The following is a description of a gene set: Extracellular hemoglobin, a byproduct of hemolysis, can release its prosthetic heme groups upon oxidation. Blood plasma contains proteins that scavenge heme. It is estimated that about 2–8% of the heme released in plasma becomes ‘bioavailable’, being internalized by bystander cells. If the heme degradation capacity of a cell, represented by heme oxidase 1 and 2, cannot be ramped up sufficiently then heme signaling and reactivity puts cells under stress. Platelets are activated by heme, and macrophages switch to the inflammatory type.<br><br>Free (labile) heme accumulates in the blood stream in great amounts under pathological conditions like viral infections and malaria, but also ARDS amd COPD. The locally affected cells' primary reaction is to upregulate heme oxidase 1 (HMOX1) expression. HMOX1 induction in these cells not only removes heme from circulation but also triggers a functional switch toward the anti-inflammatory phenotype. However, heme scavenging and degradation systems may get overwhelmed by the sheer amount of heme present.<br><br>Heme promotes platelet activation, complement activation, vasculitis, and thrombosis. Heme was recognized to act as a danger signal, damage-associated molecular pattern (DAMP), or alarmin and was shown to activate Toll-like receptor 4 (TLR4) signaling. It also has a role as corepressor in the circadian clock system. BACH1 is regulated by heme in a cell, thus placing heme as a signaling molecule in gene expression in higher eukaryotes. The regulation of BACH1 by heme may be important for the stress response in general.<br><br>Extracellular hemoglobin, a byproduct of hemolysis, can release its prosthetic heme groups uponoxidation. Due to the reactive nature of free heme, the blood plasma contains proteins that scavenge heme. It is estimated that about 2–8% of the heme released in plasma becomes ‘bioavailable’, being internalized by bystander cells. Failure of nearby cells to sufficientlymetabolize free heme can incite platelet activation, macrophage differentiation, and oxidative stress. part of: Cellular responses to stress Reactome Pathway: Heme signaling studied in species Homo sapiens, and this is the list of marker genes: TBL1XR1 (NCBI Gene Id 81612), PPARGC1A, CHD9, EP300, CLOCK, CLEC1B, PPARA, CRTC2, HBA1, NCOA2, TLR4, MEF2C, APOB, HBB, MEF2D, HELZ2, CREB1, ATF2, SLC46A1, NCOR1, NCOA6, MAFK, RAI1, LY96, NFE2L2, NPAS2, NRIP1, CARM1, MED1, XPO1, NR1D1, SIRT1, NCOA1, RXRA, TGS1, APOA1, SMARCD3, BMAL1, CRTC3, CRTC1, HDAC3 (NCBI Gene Id 8841), TBL1X, CREBBP, HMOX1, BACH1, RORA, PGRMC2